The following is a description of a gene set: The series of molecular signals initiated by neurotrophin binding to its receptor on the surface of a target cell, and ending with the regulation of a downstream cellular process, e.g. transcription. Neurotrophins are a family of secreted growth factors that induce the survival, development, and function of neurons. studied in species Homo sapiens Human Gene Set: GOBP_NEUROTROPHIN_SIGNALING_PATHWAY, and this is the list of marker genes: NTRK1, PTPN11, DDIT4, BCAR1, SPRY2, AKT1S1, KIDINS220, SHOC2, CORO1A, HAP1, NTRK3, CYFIP1, CD2AP, PPP2R5B, TMEM108 (transmembrane protein 108), DOCK3, BDNF, RAPGEF2, GFRA1 (NCBI Gene Id 2674), ZFYVE27, NTRK2, DOK5, NTF4, AGTR2, RAP1A, SPRY1, ZDHHC17 (NCBI Gene Id 23390), NDN, CYFIP2, CASP3, NGF, SORT1, WASF1, RAPGEF1, MAGI2, SOS1, RAF1, AGT, NTF3